The following is a description of a gene set: studied in species Homo sapiens Reactome Pathway: Biosynthesis of DPAn-6 SPMs part of: Biosynthesis of DPA-derived SPMs The biosynthesis of specialised proresolving mediators (SPMs) derived from the ω-6 isomer of DPA, DPAn-6 (cis-4,7,10,13,16-docosapentaenoic acid) is described here. The products of the ω-6 isomer were characterised by analogy in structure and action to docosahexaenoic acid (DHA)-derived and eicosapentaenoic acid (EPA)-derived resolvins., and this is the list of marker genes: ALOX12 (arachidonate 12-lipoxygenase, 12S type), ALOX15